The following is a description of a gene set: studied in species Mus musculus electronically inferred by orthology from the curated human pathway Reactome Pathway: Erythropoietin activates RAS This event has been computationally inferred from an event that has been demonstrated in another species.<p>The inference is based on the homology mapping from PANTHER. Briefly, reactions for which all involved PhysicalEntities (in input, output and catalyst) have a mapped orthologue/paralogue (for complexes at least 75% of components must have a mapping) are inferred to the other species. part of: Signaling by Erythropoietin, and this is the list of marker genes: Epo, Irs2 (insulin receptor substrate 2), Epor, Shc1, Vav1, Grb2